Given this list of marker genes PTGIR (prostaglandin I2 receptor), TBXA2R, PTGFR, PTGDR2, PTGER2, PTGER3, PTGER4, PTGDR, PTGER1, here is a description of the gene set: Human Gene Set: REACTOME_PROSTANOID_LIGAND_RECEPTORS Prostanoid ligand receptors species: Homo sapiens